Given this list of marker genes COMMD1, BTN3A1, GABBR2, DAZAP2, PDZD11, here is a description of the gene set: species: Homo sapiens Genes predicted to be targets of miRBase v22 microRNA hsa-miR-4737 in miRDB v6.0 with MirTarget v4 prediction scores > 80 (high confidence targets). Human Gene Set: MIR4737 from publication Chen Y, Wang X (PMID 31504780)